Given this list of marker genes TCF7L2, TCF7, GSK3B, APC (NCBI Gene Id 324), AXIN1, AXIN2, CCND1, BIRC5, CTNNB1, LEF1, MYC, TCF7L1, here is a description of the gene set: Human Gene Set: KEGG_MEDICUS_VARIANT_MUTATION_INACTIVATED_APC_TO_WNT_SIGNALING_PATHWAY Pathway Definition from KEGG: (GSK3B+AXIN) // APC* // CTNNB1 -> TCF/LEF => (BIRC5,MYC,CCND1) studied in species Homo sapiens Mutation-inactivated APC to Wnt signaling pathway. Pathway ID: N00057. Pathway type: Variant. Pathway class: nt06260 Colorectal cancer.